The following is a description of a gene set: Catalysis of the hydrolysis of a peptide bond not more than three residues from the N- or C-terminus of a polypeptide chain, in a reaction that requires a free N-terminal amino group, C-terminal carboxyl group or both. Human Gene Set: GOMF_EXOPEPTIDASE_ACTIVITY species: Homo sapiens, and this is the list of marker genes: METAP1D, ENPEP, NPEPPS, CNDP2, MEP1A, DNPEP, XPNPEP2, CPA1, FAP, VASH1, SCRN2, CPA3, DPP3, DPP10, ANPEP, NAALAD2 (N-acetylated alpha-linked acidic dipeptidase 2), XPNPEP1, PRCP, MATCAP1, CTSA, DPP6, KDM8, ACTMAP, RNPEPL1, AGBL3, CPVL, CPO, CPZ (carboxypeptidase Z), CPXM1, LTA4H, ADAM10, DPP7, CNDP1, CPA4, DPEP1 (NCBI Gene Id 1800), NPEPL1, TPP2, ERAP1, ADAM17, F11, PEPD, DPEP2, AGTPBP1, CPM, DPP4, MME, CTSC, TRHDE, MINDY1, XPNPEP3, DPEP3, AOPEP, NPEPPSP1, RNPEP, MMP15, SCPEP1, PM20D2, DPP9, ACE, HPN, CTSZ, CPB2, MMP14, CPE, SCRN1, PREP, SCRN3, LNPEP, GGH, ERMP1, AGBL2, BLMH, NAALADL1, METAP1, CPD, FOLH1B, ATG4D, CPA6 (NCBI Gene Id 57094), ERAP2, CPN1, AGBL5, JMJD7, PRSS16, LAP3, RCE1, MATCAP2, AGBL4, FOLH1, CPA5, NUDT16, DPP8, VASH2, MMP17, CPB1, MINDY2, MMP16, ACE2, METAP2, CTSH, AEBP1, LVRN, CPQ, CPA2, TPP1, CPXM2 (carboxypeptidase X, M14 family member 2), ZMPSTE24, AGBL1, GPC3